Given this list of marker genes ECI2 (enoyl-CoA delta isomerase 2), BPTF, KANSL1, FABP5P9, WAC, TRAPPC3L, DMTF1, EID2, CHD3, RRM2 (NCBI Gene Id 6241), PACS1, UCHL3, CRLS1, POLR3H, RBM34, GPC6, MTND1P15, OCA2, TCEAL1, MT-TE, GUCY1A1, FBXO8, PPP2R5E, CHIC2, EVA1A, NTPCR, R3HDM2, MIR4733, CYP1B1-AS1, SNX2, FIRRE, ARHGAP21, SLC25A20, PIK3R4, RNVU1-33, MCM10, MAST2, ZNF138, HLA-DMB, LINC01625, TRIM2, PCK2, LINC02683, GLRX (glutaredoxin), KLHL25, NRGN, SMAD1, FGD2, HOXB7 (homeobox B7), ENSG00000215156 (novel protein), LTBP4, SPG11, WRAP73, MAT2B (methionine adenosyltransferase 2 non-catalytic beta subunit), EDC3, C7orf50, MANEA, SEM1, PKD2L2, SLC38A6, ABHD17AP3, MED14, DTWD2, XIAP, MIR5188, RPL32P22, PEX2, LOXL3, GDI2, ERCC6L2, HDAC2, RGS12, FAM3C, RPL10A, SERTAD3, LPIN1, HOXD11 (homeobox D11), CDKAL1, SEMA4F, LINC01339, MTX2, PRKAG2, SCTR, STX18, SLC41A3, SENP8, UNC45A, MRPL42, PSMB5 (NCBI Gene Id 5693), MGC32805, SYT1, PAOX, MED23, RAPGEFL1, LCA5L, DNA2, PHF21A, PSMA4, MT-TW, CLN5, HOXB3, TOMM20, MIR7849, SCAT2, TARDBP, LINC01551, NT5C3B, PIF1, AHSA1, RTRAF, MIR301A, WNT5B, IPO7, ITGB1BP1, NFKB2, CFAP96, PCNP, SALL2 (spalt like transcription factor 2), H3-3A, CELA2B, TNFRSF1A, OSBPL9, FBXL18, LONP2, CEP76, ANKRD37, ETV4, YBX1P9, ADGRG6, LINC01031, SVOPL, TIMELESS, HNRNPF, TYRO3P, EFL1, GASK1B, COPS6, B4GALT3, MIEF1, KRT8P9, DHX34, ARHGEF2, RANBP17, EDARADD (NCBI Gene Id 128178), SBF2, HLA-L, TRMT11 (NCBI Gene Id 60487), NF1, AOPEP, PLEKHH3, TRAM2, INO80D, SPATS2L, TRPC1, ENSG00000249690, IBA57-DT, CCSER2, ZDHHC22, RERE, RBM8A, CDK5R1, ESS2, ATF7-NPFF, CCM2, NCOA7-AS1, KCNK5, MATR3, FAM66B (NCBI Gene Id 552865), TBC1D32, RPS27A (ribosomal protein S27a), EEF1E1-BLOC1S5, TAF4B, TUBB2B, ENSG00000232732, SLC25A3, MTFMT, TMEM248, CYRIB, GCNT2, PTRHD1, YIPF1, GFI1, UBR4 (NCBI Gene Id 57525), COPG2, ZNF767P, ADAM15, STMP1, RPL21P115, MT-TL2, MT-TR, C21orf58, GFPT1, DCAF10, MTHFD1L, LINC02362, PSIP1, SERBP1, TOP1MT, ALAD, BORCS7, HERC6, MESD, PAQR8, FTH1P20, LINC00426, LRRC75B, RNU6-363P, GOLGA4, UMPS, DCTPP1, GALNT11, SPATS1, BEGAIN, SINHCAF, LBR, PAFAH1B1, EXO1, PDE7B-AS1 (PDE7B antisense RNA 1), ALDH3A2, MTCO3P12, RHCG, MALAT1 (NCBI Gene Id 378938), CEP250, DENND10, MT-ND1, VOPP1, ENSG00000247416, SMAD5, SLC17A1, DLSTP1, MT-TP, STARD3, EPHA4, FOXJ3, MAP4K3-DT, TFAM, LIMS1, WWOX, LGMN, SLC12A9, PEX14, UBR3, ACADM, KDM3B, FES, ARMC3, SNX29, SLC25A16, MARCHF2, BCL7C, SEMA3A, SIDT2, LINC01841, FBXL3, DHX8, C2orf69 (NCBI Gene Id 205327), GTF2B, RPS26P29, MRPS21, LEPR, RNA5SP72, MIPOL1, UROD, MIR6508, PLA1A, MRPL45, EFCAB5, CMKLR2, CCNH, LRRC8D, CHEK1, CSTF3, TCP11L2, ZNF304, GNB3, HCG27, MBNL2, RTP3, RPSAP52, RNA5SP194 (NCBI Gene Id 100873456), MINDY3, NR2E3, DDAH1, LIN9, PPTC7, RNA5SP18, NBN (nibrin), TKTL1, CEP128, SMC1B, HMGA2, GPR161, CDK5RAP3, TBC1D3P7, NAT10, MSRB3-AS1, ZNF143, PYCR3, MLLT10, SASH1, CDNF, MYB, RNU6-213P, SMIM12, ERLIN2, PIAS1, MIR374B (microRNA 374b), TRDMT1, CD300LG, USP28, CTF1, PER2, THAP4, MICAL3, NOD1, CPEB4, CDX1, MIR1302-3, SEMA4G, RPL35AP28, IBA57, RAB13, GCC2, SERTAD3-AS1, RNU1-89P, SS18, EFCAB2, TP53BP2, APH1A, UBE2Q2P1, LAMTOR3P1, ZNF48, UTS2R, WDR11, PRPF18, CDKN2D, MBD6, SRSF11, ENSG00000261632, TMF1, SKA2, MRPL22 (NCBI Gene Id 64992), NRG3, ATP5F1A, CXXC5, RN7SL535P, NABP2, HLA-DQB1, GSTM2, HM13-IT1, PBX3, CREB3L2 (cAMP responsive element binding protein 3 like 2), MAP3K4-AS1, SUMO1, CCT3, GBA1, LINC00682, AGPAT1, MAPK6, SLC4A5, MAP1A, IDH2, SEMA3C, EID2B, AGL, MIR3688-1, UBA52P5, DENND1A, CD2AP, PPP4R2, LRRC23, LINC01611, MT-ND3, NRL, ENSG00000260288, LINC00687, RCOR3, MARCHF7, BEND3P1, REV3L, DIS3L, GYS1, SETD2, TUBA1B, NSMAF, TRAF3IP2-AS1, MEIG1, DPH5, VOPP1-DT, SLC7A6, STPG1, MORF4L2, EIF3B, METTL22, RNVU1-34, HOXB-AS3, KIAA1217, LYRM2, KLRC4-KLRK1, NFRKB, NUP93, RDH11, LINC01605, DZIP1, MT-ND4L, ENSG00000235066, RPS15, GAS7, OPN4, TBC1D7, SYN3, LINC01873, MYL11, MIR6833, KANSL3, CLTCL1, MARS2, CECR2, CATSPERE, MISP3, RMI2, KDM4A-AS1, TLK2, ADRA1A, EEF1A1, MCM8, CENPO, ZNF623, PGPEP1L, PRCC, UBR2, ZP3, MT-TL1, GDPD1, CYSTM1, IFIT2, MIR421, SMC3P1, NAXE, TRAPPC11, FRS2, MMS22L, KAT7, SLC25A33, MCRIP1, ZPLD1, TTC39A, RNA5SP283, PPP1R27, TST, GGH, RIOK3, CLK1, SGO2, NVL (NCBI Gene Id 4931), MT-TG (mitochondrially encoded tRNA-Gly (GGN)), FBXL17, MT-CO1 (mitochondrially encoded cytochrome c oxidase I), TM2D3, MIR542, PACSIN2, RHOQ, ENSG00000260830, BIN3, FBXW11, RNU7-79P, HECTD3, COX6A1P2 (COX6A1 pseudogene 2), DEPDC1-AS1, CASP2, VTRNA2-1, RN7SL254P, C1orf198, WHAMM, CHSY1, MBOAT2, CTNNA1, HMCN2, MIR6130, FBXO28, RPL7AP42, CALHM6-AS1, CYTH1, AJUBA, MRPL58, HIVEP1, AMZ1, FYN, ZKSCAN4 (zinc finger with KRAB and SCAN domains 4), LINC00933, WSB1, MCM9, RNU6-416P, MT-TH, SYS1, RNU4-27P, ENSG00000248112, KIF6, RPL36AP28, EVI5, ELP2, UBE2Q1, RPLP1 (ribosomal protein lateral stalk subunit P1), TMEM14B, DOCK7, MAP9-AS1, LINC00364, UBC, TBC1D13, FKBP3, RNU6-1067P, MIR4456, TXNRD1, RESF1, FBXO32, GNB5, NCKAP5L (NCK associated protein 5 like), UPF3B, RHOU, ANKRD40, SFXN4, ACAN, CTDSPL, MIR3145, TLCD5, ZSCAN26, TAGLN2, RUFY1, MKS1, ARID5B, DTNBP1 (dystrobrevin binding protein 1), PSME3, PRDX1, DNAJC1, SLC35B4, RN7SL336P, ALG9, MT-TS2, ENSG00000252722, DHX30, CARMIL1, ALDH1A2, LINC00358, ECH1, PRKAR1A, MAPT, RBBP9, CDO1, ANAPC7 (NCBI Gene Id 51434), PPFIBP2 (NCBI Gene Id 8495), HSPA12A, SKIDA1, SKAP2, RPS9P1, SPATA24, RN7SL749P, VPS28, CDC7, NEIL1, ZCCHC8, FAM114A2, SNX6, DDX60L, DCP2, PPM1G, RPRD2, CENPT, HSPA14, KANSL1-AS1, MT-ND5 (NCBI Gene Id 4540), UVRAG, NBPF1, TFRC (NCBI Gene Id 7037), CCDC183-AS1, COCH, GARNL3, EEF1E1, KLRK1, TRAM2-AS1, TXNDC15, DAPK2, ACAA2, SERAC1, BLOC1S2, PTPN13, STARD7, KCTD20, CDC27, SCAPER, STAU2, RBCK1, ERMAP, ARIH1, TMEM184B, RPL21P136, TIMM44, ATG5, DDX52, MEMO1P1, SULT2B1, NOPCHAP1, TXLNB, VCAN, TARS3, TMEM169, RUVBL1, STMN1, MT-TQ, ADAR, CHRM3-AS2, RNU6-225P, RN7SL108P, HOXD3, MAN2A2, ATG14, PSMB6, WDR11-DT, THBS1-IT1, PDK2 (pyruvate dehydrogenase kinase 2), ARHGEF2-AS1, AGPS, GPR137, MAPDA, SF3B4, SNX9, SLC39A10, RNY1P5, DDIT3, NDUFC1, AVPI1, CBY1, LNPEP, KLHL8, ELOCP33, CA14, MT-TF, NEPRO-AS1, UTP6, MTA2, UBL7, MT-ND4, STAT1, IQCH (NCBI Gene Id 64799), STAG1, TACSTD2, RNA5SP86, RN7SKP43, ABI1, GUSBP18, ARMH3, AMZ2P1, FAM230G, RBM33, TXLNA, DUSP5, CRIPT, NFATC3, TPI1, MEF2C, RNU6-1061P, ABRAXAS1, SEPTIN8, TBC1D2B, RGCC (NCBI Gene Id 730127), CHD8 (NCBI Gene Id 64329), COX5B, SDCBP2, SLC6A15 (NCBI Gene Id 59276), ERI3, PDS5B, TIAM2, RPL34, RAB33B, BORCS7-ASMT, ACP7, USP33, CCDC178, SMAD1-AS1, NUDT12, PLA2G6, CHRM3, CDC42SE2, SLC22A23, ACAT2, STAU2-AS1, C19orf12, FUT11, MVD, MADD, SLC2A3, DDX18, RNU6-1102P, STOX2 (NCBI Gene Id 93007), NR2F2, SCARNA2, MPP3, XPA, FARSA, RARS1, LINC-PINT, ACOX2, TFAP2A, LSM6, CEP131, PAFAH2, GNA12, PKM, KLHL10, ING1, HBZ, HMGB1P20, LRRC37A3, MT-RNR1, HASPIN, TMEM60, TCF24, MT-RNR2, DIO1, SMURF1, HNRNPCP9, CCDC137P1, EXD2 (NCBI Gene Id 55218), MIR3649, LINC01596, RPL21P111, CD247, B4GALT6, LINC00518, RPL23AP53, RN7SL395P, TFG, DST, RNU6ATAC22P, HNRNPC (heterogeneous nuclear ribonucleoprotein C), DNAJA4, COMMD4P1, PGM2L1, RN7SL418P, MT-TT, COPS7A, EPHB4, SUOX, ING4, MT-TV, MAPRE2, SCAMP3, MMAA, FILIP1, PSMD1 (proteasome 26S subunit, non-ATPase 1), KLHDC8B, MGRN1, TIMMDC1, APOO, MSGN1, CSK, BAHCC1, HLA-DQA1, NCOA4, MAP3K8, STK38, CASP3, AFF4 (ALF transcription elongation factor 4), CACYBPP1, MIR3907 (microRNA 3907), TAF6, KRT18P13, SDHA, C18orf21, UBE2E1, MTG1, MT-TI, MIR4633, CYP11A1, PI4KB, here is a description of the gene set: from publication Yevshin I, Sharipov R, Kolmykov S, Kondrakhin Y, Kolpakov F (PMID 30445619) Human Gene Set: PSIP1_TARGET_GENES species: Homo sapiens Genes containing one or more binding sites for (PSIP1) in their promoter regions (TSS -1000,+100 bp) as identified by GTRD version 20.06 ChIP-seq harmonization.